Given this list of marker genes BDNF, GPS2, PRKACA, HDAC1, SIN3A, CALM1, MECP2, NCOR1, HDAC3, TBL1X, NCOR2, CAMK4, TBL1XR1, here is a description of the gene set: studied in species Homo sapiens Human Gene Set: REACTOME_LOSS_OF_FUNCTION_OF_MECP2_IN_RETT_SYNDROME Loss of function of MECP2 in Rett syndrome